Given this list of marker genes VWF, PCDHB9, MACROD2, HTR2A, ZFHX2, DHRS12, ZNF582, ZNF766, CAVIN2, SLC8A3, RECQL5, EREG, FAM83B, ZNF667, MYL4, CISH, JCAD, SLC25A51, PFN2, TBC1D16, IPO8, THEM4, ISCA1, TBC1D31, TNPO3, ZNF560, APIP, CLIC2, NTN5, MRPL55, GPR6, DOK6, DAAM2, SLC38A10, CHCHD2, SCG5, ZFP28, FOXJ1, ELAVL2, MAP7D3, CFAP184, TAF3, CDX4, TADA2B, MSRB3, SAP30BP, FSTL1, CANT1, TUBB6, PIGZ, SYDE2, FCRLB, GTF2A1, PHF13, PCDHGA5 (protocadherin gamma subfamily A, 5), ARHGAP44, PDHX, YBX3, GAN, TEK (NCBI Gene Id 7437), WBP1L (NCBI Gene Id 54909), SORL1, BTBD3, GDF3 (NCBI Gene Id 9573), RSKR, ZNF281, WT1-AS, GPAT4, GPRASP3, TLR2, NNAT, ZNF875, PMAIP1, ZCCHC12, TIGD3, ZBTB14, MAP7D2, FAM3A, MCTS1, PCDHB16, MAP7, ZFP3, GSN-AS1, TIE1, ENDOD1, ADGRG6, SLC39A14, RIPPLY3, ICA1L, ZNF662, TXNRD3, WT1, PABPN1, MOS, GNG11, KRT81, N4BP1, LBX2, ZNF264, CENPV, CXCL1, POU5F1, NEUROG1, CCDC34, IL11RA, VPREB3, DNM3, VPS53, PAQR5 (progestin and adipoQ receptor family member 5), SMIM15, VWA5A, TMEM263, ABLIM1, PRRG1, JAKMIP2, ZSCAN1, CD9, CYP26C1, HNRNPR, CRHBP, GPR149, OXA1L, here is a description of the gene set: from publication Figueroa ME, Lugthart S, Li Y, Erpelinck-Verschueren C, Deng X, Christos PJ, Schifano E, Booth J, van Putten W, Skrabanek L, Campagne F, Mazumdar M, Greally JM, Valk PJ, Löwenberg B, Delwel R, Melnick A (PMID 20060365) Human Gene Set: FIGUEROA_AML_METHYLATION_CLUSTER_1_UP species: Homo sapiens Cluster 1 of aberrantly hypermethylated genes in blasts from AML (acute myeloid leukemia) patients. We hypothesized that DNA methylation distributes into specific patterns in cancer cells, which reflect critical biological differences. We therefore examined the methylation profiles of 344 patients with acute myeloid leukemia (AML). Clustering of these patients by methylation data segregated patients into 16 groups. Five of these groups defined new AML subtypes that shared no other known feature. In addition, DNA methylation profiles segregated patients with CEBPA aberrations from other subtypes of leukemia, defined four epigenetically distinct forms of AML with NPM1 mutations, and showed that established AML1-ETO, CBFb-MYH11, and PML-RARA leukemia entities are associated with specific methylation profiles. We report a 15 gene methylation classifier predictive of overall survival in an independent patient cohort (p < 0.001, adjusted for known covariates).